Given this list of marker genes Junb, Clk1, Hspa1a, Klf2, Klf6 (Kruppel-like transcription factor 6), Jun, Hspa1b, here is a description of the gene set: species: Mus musculus Mouse Gene Set: CUI_T_CELL_CD4_TGF_BETA_1_RESPONSE_DN from publication Cui A, Huang T, Li S, Ma A, Pérez JL, Sander C, Keskin DB, Wu CJ, Fraenkel E, Hacohen N (PMID 38057668) Genes negatively differentially expressed in cell type: CD4+ T cell upon treatment with cytokine: TGF-β1 in mouse lymph nodes in vivo. Cytokines mediate cell-cell communication in the immune system and represent important therapeutic targets. A myriad of studies have highlighted their central role in immune function, yet we lack a global view of the cellular responses of each immune cell type to each cytokine. To address this gap, the authors created the Immune Dictionary, a compendium of single-cell transcriptomic profiles of more than 17 immune cell types in response to each of 86 cytokines (>1,400 cytokine-cell type combinations) in mouse lymph nodes in vivo. A cytokine-centric view of the dictionary revealed that most cytokines induce highly cell-type-specific responses. For example, the inflammatory cytokine interleukin-1β induces distinct gene programmes in almost every cell type. A cell-type-centric view of the dictionary identified more than 66 cytokine-driven cellular polarization states across immune cell types, including previously uncharacterized states such as an interleukin-18-induced polyfunctional natural killer cell state.